Given this list of marker genes CLSTN3 (calsyntenin 3), IL18, POLR3E, ZNF625 (zinc finger protein 625), ATM (NCBI Gene Id 8068), DCTN6, SERINC1, HPGD, TAS2R5, LMO4, PSMC5, CDC73, PHF12, CHD1, TOB1, CXCR4, PNN, TNKS2 (NCBI Gene Id 94771), TRIM23, ZFP91, RABGGTB, NDC80, HIF1A, CXCL8, ELAC1, SMNDC1, SNRPE, HSPA13, PDE4B, ZNF267, DNTTIP2, CBLB, PTBP2, ACAD9, NIBAN1, TNFAIP3, RUNX1, PRPS1, ZBTB1, PER1, ZKSCAN1, TRIM13 (NCBI Gene Id 93520), LITAF, WDR26, SOD2, CD55, SMAD3, NKRF, TTC32, SRGN, ID2, YES1, RSRC2, STIM1, IDS, INSIG1, ZNF451, JARID2, B4GALT4, NAMPT, CLK1, CDKN2C, DLL1, RNF103, MPP7, ZNF394 (NCBI Gene Id 84124), PTP4A1, RTF1, DUSP12, ADNP2, IRS2, CCNE1, HNRNPA3P1, FN1, AGFG1, MTREX, CASP3, CCNL1, UVRAG, SEC63, CRH, GNG10, CDKN1B, DYRK1A, THBD, ANKLE2, G0S2, SLC7A5, PRKCH, ZFP36L2, PFKFB3, KDM6A, PIP5K1A, GALNT3, CRYBG1, RIPK2, P2RY10, PPM1A, HERC1, NDUFV2, LUC7L3, ATP1B3, TNC, SNIP1, MXD1, TLE1, PLAT, GADD45A, ZNF281, UQCRFS1, MAP4K5, SLC16A6, LPIN1, SESN1, TMED10, SETD2, CD47, RGPD5, DCAF11, ATG2A, CLEC2B, PTPN22, IFNGR1, CSNK1A1, SC5D, RASA2, BTG3 (BTG anti-proliferation factor 3), MXI1, ARID5A, ETS2, SAR1A, S100P, ACBD5, ETF1, TAF13, BCL2A1 (BCL2 related protein A1), IL13, USP14, HCK, HBP1, ERH, RBBP6, AFAP1, STRAP (NCBI Gene Id 11171), CFI, SBDS, AREG, PRKDC, ADM, CXCR2, HERPUD1, PRMT3, HMCES (5-hydroxymethylcytosine binding, ES cell specific), FNBP4, LAMTOR5, CRTAM, USP48, PPM1B, NR4A2, PIK3R1, OSGIN2 (oxidative stress induced growth inhibitor family member 2), ZNF326, EIF1B, COL4A5, PDK4 (NCBI Gene Id 5166), MCL1, CREM, UBE2D3, TGFBR3, here is a description of the gene set: Gene expression in human peripheral blood mononuclear cells was systematically evaluated following smallpox and yellow fever vaccination, and naturally occurring upper respiratory infection (URI). All three infections were characterized by the induction of many interferon stimulated genes, as well as enhanced expression of genes involved in proteolysis and antigen presentation. Vaccinia infection was also characterized by a distinct expression signature composed of up-regulation of monocyte response genes, with repression of genes expressed by B and T-cells. In contrast, the yellow fever host response was characterized by a suppression of ribosomal and translation factors, distinguishing this infection from vaccinia and URI. No significant URI-specific signature was observed, perhaps reflecting greater heterogeneity in the study population and etiological agents. Taken together, these data suggest that specific host gene expression signatures may be identified that distinguish one or a small number of virus agents. Human Gene Set: SCHERER_PBMC_APSV_WETVAX_AGE_18_32YO_50_TO_60DY_UP Genes up-regulated in peripheral blood mononuclear cell (50 to 60)d vs 0d in adults (18-32) after exposure to APSV Wetvax, time point 50 to 60D species: Homo sapiens from publication Scherer CA, Magness CL, Steiger KV, Poitinger ND, Caputo CM, Miner DG, Winokur PL, Klinzman D, McKee J, Pilar C, Ward PA, Gillham MH, Haulman NJ, Stapleton JT, Iadonato SP (PMID 17651872)